The following is a description of a gene set: from publication Williams MA, Ravkov EV, Bevan MJ (PMID 18356084) species: Homo sapiens Human Gene Set: GSE10094_LCMV_VS_LISTERIA_IND_EFF_CD4_TCELL_DN Genes down-regulated in comparison of CD4 T cells from mice challenged with LCMV versus those challenged with Listeria-gp61. Following infection with LCMV, CD4+ SMARTA TCR transgenic cells (specific for the gp61-80 epitope of the LCMV glycoprotein) rapidly expand, become effector cells, and go on to form a long-lived memory population. Following infection with a recombinant Listeria monocytogenes expressing the LCMV epitope gp61-80, SMARTA cells also expand but display defective effector differentiation and fail to form memory. In an attempt to understand the signals required for CD4 T cell memory differentiation, we compared gene expression by SMARTA cells at the peak of the primary response following either Lm-gp61 or LCMV infection., and this is the list of marker genes: ANO1, NKX2-1 (NK2 homeobox 1), MYO10, LRRN4CL, HTR4, SYCP2, SORCS3-AS1, MEFV, UFC1, NPC2, FLT3, PIBF1, RBP3, IQSEC3, SLC35E4, ALOXE3, CFI, CLN8, ACCSL, JHY, RUNDC3A, HACD4, PDZD11, ISL2 (NCBI Gene Id 94725), AEBP1, RHAG (NCBI Gene Id 6005), SS18L1 (NCBI Gene Id 26039), CALML3, PLIN5, TMEM259, GABRA1, SLC29A3, ZNF862, MSR1, CCL4, S100A8, CLIC6, DEUP1, H2AJ, FHL5, BMP7, C3orf52, SYNGR4, TGIF2, ADCY6, RPL39, UTS2R, CRISP1, STEAP1, MLPH, LTB4R, KCNE5, RPTOR, KCNA7, G6PC1, ATP7B, NHSL3, AMH, AP5B1 (adaptor related protein complex 5 subunit beta 1), RDH16, LAMTOR1, FGL1, TMEM207, PNPLA3, DND1, ZNF112, NEUROD1, TMEM171, TMEM160 (transmembrane protein 160), BDNF, ABCA12, IFTAP, ATF3, MUC13 (NCBI Gene Id 65118), CIART, NPC1L1, LAYN, CXADR (CXADR Ig-like cell adhesion molecule), NTNG1, SLC25A31, RBM25, ARHGEF11, DYNC2I1, SLC12A9, MS4A8, SPNS3, TMEM92, SNAI3, TRANK1, PCDHB14, PTOV1, ZNF394, C12orf57, INAVA, KCNJ6, OAZ1, SNORD104, GALR3, ST3GAL1, XKRX, GIT1, KCTD1, PPIA, PARM1, LCAT, AQP6, ZNF483, PHGR1, SYNDIG1L, RBMS3, ZFP36, HAP1, WIPI1, NRP2, ADPRS, DAZ2, GNG8, NDUFAF8, CA8, RIBC1, ISX, PRSS36, SLC25A2, PIGO, NLRP10, GLRB, ANK1, ZNF532, FLG (filaggrin), EPHB3, ESRP1, SCTR, CLEC7A (C-type lectin domain containing 7A), HS3ST4, KRTCAP2, HS3ST3A1, FXR2, IFNGR2, FLRT2, LTB, NUDT14, PLA2G3, SIGLEC1, IGLON5, INS, TMEM88, NEK6 (NCBI Gene Id 58167), MGST1, BET1L, ELAPOR2, RHBDD3, PIM1, ARHGAP23, FUT2, PTCH2, HYOU1, B4GALNT2, ZNF334, PATL2, SLC6A2, FITM1, SLC5A10, TRPM2, UBXN2B, PCDHB3, WFDC1, SEL1L2, PRPF19, P2RX1, CHMP4C, PCYT1A, SMTNL2, ADRA1A (adrenoceptor alpha 1A), MYOM1, HNRNPF, ROBO1, LGI4, REG3G (NCBI Gene Id 130120), UCP2, PLAAT1, FAM171A1, ENOX1, PKP1, SLC15A5, INSRR, CAMK2N1, TLR9 (toll like receptor 9), RABAC1, MUTYH (NCBI Gene Id 4595), USP50, GDF9, PCDH10, PKMYT1, RBM39, HSD17B3, PTMS (NCBI Gene Id 5763), OSBPL6, TMEM116, ZHX3, KCNH3